The following is a description of a gene set: Neighborhood of HPN studied in species Homo sapiens Neighborhood of HPN hepsin (transmembrane protease, serine 1) in the GNF2 expression compendium Human Gene Set: GNF2_HPN, and this is the list of marker genes: F2, HMGCL, ADH1C, CIDEB, HABP2, ORM1 (NCBI Gene Id 5004), FTCD, ATF5, C6, ITIH4, ADH6, KHK, SLC25A10, AKR7A3, NNMT, AGXT, CYP2E1, TMPRSS6, ALDH1L1, CYP2C8, C8B, FAH, SDS, C8A, QPRT, CES1, ITIH1, PIPOX, SERPINA6, APOC4, ZGPAT, HAAO, C4BPB, MAT1A, SLC38A3, TMEM176A, AMBP, F12, IGFALS, PON1, UPB1, GSTZ1, PEMT, RDH16, SLC22A7, ANG, RARRES2, APOC2, UGT2B28, MASP2, TKFC, VTN, GAMT, APOC3, AHSG, HMGCS2, PROC, SLC27A5, APOF, CFB, DCXR, HRG, ALDOB, CYP2B6, PCK1, SERPIND1, FETUB, CYP2A6, TST, SLC22A1, HPD, SERPINA4, APOC1, SERPING1 (serpin family G member 1), PON3, CPN2, CYP1A2, HSD17B6, ASS1, CYP2C9, F10, SAA4, SHMT1, CDHR5, PXMP2, ACSM2A, HPX, ANGPTL8, PRODH2, CYP4F2, CYP27A1, PLG, ABCC6, CYP4F12, C3, ASGR2, SPP2, ITIH3, HPR, GSTM1, APCS, SARDH, CYP2D6, TAT, ZG16, APOA2, CYP4A11, APOH, CYP4F11, HPN, TMEM176B, ORM2, LCAT, RBP4, ASL, CES2, C8G, ACOX2, C4BPA, GNMT, APOA1, SERPINF2, PCK2, ECHS1, SERPINC1 (NCBI Gene Id 462), CEBPA, HAMP (hepcidin antimicrobial peptide), GJB1, GSTM2, ALDH4A1, SLC10A1, HP, TM4SF5, HGFAC